The following is a description of a gene set: Genes that have high expression in mammary tumors of squamous epithelium histology. species: Mus musculus Human Gene Set: HOLLERN_SQUAMOUS_BREAST_TUMOR Human breast cancer has been characterized by extensive transcriptional heterogeneity, with dominant patterns reflected in the intrinsic subtypes. Mouse models of breast cancer also have heterogeneous transcriptomes and we noted that specific histological subtypes were associated with particular subsets. We hypothesized that unique sets of genes define each tumor histological type across mouse models of breast cancer. Using mouse models that contained both gene expression data and expert pathologist classification of tumor histology on a sample by sample basis, we predicted and validated gene expression signatures for Papillary, EMT, Microacinar and other histological subtypes. These signatures predict known histological events across murine breast cancer models and identify counterparts of mouse mammary tumor types in subtypes of human breast cancer. Importantly, the EMT, Adenomyoepithelial, and Solid signatures were predictive of clinical events in human breast cancer. In addition, a pan-cancer comparison revealed that the histological signatures were active in a variety of human cancers such as lung, oral, and esophageal squamous tumors. Finally, the differentiation status and transcriptional activity implicit within these signatures was identified. These data reveal that within tumor histology groups are unique gene expression profiles of differentiation and pathway activity that stretch well beyond the transgenic initiating events and that have clear applicability to human cancers. As a result, our work provides a predictive resource and insights into possible mechanisms that govern tumor heterogeneity. from publication Hollern DP, Swiatnicki MR, Andrechek ER (PMID 29346386), and this is the list of marker genes: SPO11, KRT17, GJB6, KRT33A, IL36RN, BMP2, ID1, KLK7, LRP4, PTBP3, JAG2, KRT86, KRTAP4-5, BMP4, KRT35, ACSBG1, APCDD1, SERPINB9, KRT5, IDE, AHR, HOPX, PLA2G2E, SLC46A2, KRT14, NFE2L3, SPRR1B, SERPINB8, CST6, PADI3, S100A14, C11orf96, AXIN2, KRT1, PADI1, ATP12A, ELOVL4, KRTAP9-9, VAV3, DLX3, LY6G6C, KRT85, PAWR, WNT6, KRT71, KRTAP15-1, SLC40A1, KRT79, KRTDAP, SFN, TUBB3, ATG9B, CUX1, ACP6, RASL11B, SERPINB11, TGM1, CYSRT1, SNCAIP, KRT81, CRYBA4, FABP5, N4BP3, GJA1, POU3F1, FGFBP1, TEDDM3P, KRT25, KRT36, KRTAP1-3, WNT10A, RALGPS2, SYT9, ASPRV1, KRT75, RDH16, IVL, KRT15, AQP3, MMP7, GATA6, PIM1 (Pim-1 proto-oncogene, serine/threonine kinase), SLCO5A1, MAL, ID3, HRNR, RDH10, HYAL1, SERPINB2, GPRC5D, PSORS1C2, TCHH, PADI4, POLR3G, KRTAP6-1, NKD1, CACNA2D3, KRT27, KRT33B (NCBI Gene Id 3884), ADH7, KLF4, PTCH2, TUBA8, MT4 (metallothionein 4), SPRR1A, CRCT1, KRTAP19-1, SLC23A3, IL24, GSDMA, KRTAP3-3, TP63, SCEL, GPR87, KRT72, PINLYP, TGM3, KRTAP8-1, GNAI1, ACOT1, CWH43, KRT80, KRT16, LIMK2, CDSN (NCBI Gene Id 56798), DST, CSTA, KRTAP3-1 (keratin associated protein 3-1), KRT34, IRX4, KRTAP4-11, KRTAP4-1, DSC1, DEFB1, ZNF703, OVOL1 (ovo like transcriptional repressor 1), GLTP (glycolipid transfer protein), LCE1B, GAS7, HOXC13, GJB5, ENDOU, GJB4, CRYM, KRTAP9-4 (keratin associated protein 9-4), CLIP4 (NCBI Gene Id 79745), KRT31, TCF7, ADTRP, MSX2, KLK6, BMP7, MT1X, CADPS, KRT10, EGR2, GATA2, CALML5, KRT6B, KRTAP13-2, CYP1B1, TRIM29, S100A3, KRT83, DEGS2, NOTUM, SOSTDC1, RPTN, CTPS1, CASP14, SP6, KRTAP5-2, PARD6G, TNFRSF19